The following is a description of a gene set: studied in species Homo sapiens Genes up-regulated in CD4 over-expressing: FOXP3 and PPARg1 form of PPARG versus FOXP3. from publication Cipolletta D, Feuerer M, Li A, Kamei N, Lee J, Shoelson SE, Benoist C, Mathis D (PMID 22722857) We identified Pparg as a major orchestrator of the phenotype of adipose-tissue resident regulatory T cells (VAT Tregs). To explore the contribution of Pparg1 and 2 in the generation of the VAT Tregs-specific gene signatures, CD4+FoxP3- T cells were transduced with Foxp3+/- Pparg1 (or Pparg2), treated with Pioglitazone or vehicle, and double sorted for microarray analysis. Human Gene Set: GSE37533_PPARG1_FOXP3_VS_FOXP3_TRANSDUCED_CD4_TCELL_UP, and this is the list of marker genes: MXI1, SRR, ABRACL, DMAC1, HSPA13, LCAT, TAF12, E2F7, GDAP2, IPO11, GKAP1, GOLGA5, JMY, DERL1, YIF1B, TENM4, EME2, PSMB4, SLC25A35, PON2, MGAT2, PNPO, SRM, THNSL2, DRC3, ACER3, QSOX2, UBN1, HOXA7, EFHD1, MAN1A2, RXYLT1, PGM2, PLA2G12A, FXN (frataxin), CXCL10, RAB5IF, MLKL (mixed lineage kinase domain like pseudokinase), SLC12A3, CCDC28B, DCTPP1, VPS25, SLC49A4, TEX30, TXNL1, TTC16, GALC, TCEAL8, NCOA2, APOA2, P2RX3, KRCC1, SVIP, SMC2, CDC14B, NSG1, NME6, SNRPA, OSGIN1, PAPSS1, PDZD4, CLIP1, ANXA7, ITGB2, FBXO17, EPRS1, GRHL1, RAD51B, ITGAL, UBE2B, PLCD1, DHRS7, BIK, COX5A, PRICKLE1, ZMAT3, MFSD11 (NCBI Gene Id 79157), DACT1, SLC25A34, GEMIN6, INHBB, MRPS12, CS, DNAJC4, PRCP, ALG14, RNASE3, PSKH1, ALG5 (NCBI Gene Id 29880), NFIL3, MAT1A, LOXL3, LRP8, NAPRT, DNM3, SERF1A, TM9SF1, EFEMP2, ZNF358 (zinc finger protein 358), ECHS1, SLC18B1, MYL4, SEC22A, PPP1R13L, MCRIP2, PTRH2, ECT2, SLC52A2, WDR7, CLDN12 (NCBI Gene Id 9069), NDUFC2, TASP1, EBP, CCNE1, GID4 (GID complex subunit 4 homolog), FAM162B, PPT2, ITIH5, MRPL54, CYFIP2, COQ3, RHOB (NCBI Gene Id 388), SRP19, GOLIM4, CNNM2, SQSTM1, TMEM41B, RNASET2, RALB, ARF1, GLMP, GNL3, PIM2, PSPH, SKIL (SKI like proto-oncogene), MAP3K20, SLC8B1, ATP5PO, NUDCD1, SEPTIN9, TMEM223, HERPUD1, ACAD8, RABEPK, ARHGEF10, SS18L2, COPB2, CPOX, UBE2E1, MAD2L1, TLE2, SHISA4, ILDR1, WDR83OS, SLC46A1, AIFM2, SH3RF1, KAT7, ITPRIPL2, TEKT2, MIF, CUBN, SMAD5, IFRD1, CRYZ, PADI4, INPP4A, FDX1 (ferredoxin 1), NSFL1C, SLC7A1, XRCC3, EBAG9, EIF2D, CHRND, PCDHGC4, HIKESHI, RAPGEF2, TIRAP, TRIP4, CMYA5, PCGF2, SRSF9, FAS, C7orf57, DUSP19, CRYBB1, DAD1, DNA2, SNX22, GALK2, HSF4, RRBP1, CRIM1, CKS2, TTC23, DHDDS, RSPH14, TCF12, ZBTB8OS, ZSCAN25